Given this list of marker genes BMP4, TPM3, SARS1, CIC, NEB, POLG, KLHL41 (NCBI Gene Id 10324), TYMP, KANSL1, TUBB4A, STRADA, COL6A1, GRIA3, MED12, NSDHL, KBTBD13, TPM2, UPF3B, POLR3A, ACTA1, DNA2, FBN2, HERC1, MYPN, TNNT1, TIMM50, NONO, TGFB1, FARSB, WRN, here is a description of the gene set: Slender build Asthenic habitus refers to a slender build with long limbs, an angular profile, and prominent muscles or bones. species: Homo sapiens Human Gene Set: HP_SLENDER_BUILD